The following is a description of a gene set: studied in species Homo sapiens The directed movement of chromosomes in the center of the spindle towards the spindle poles, mediated by the shortening of microtubules attached to the chromosomes. Human Gene Set: GOBP_CHROMOSOME_MOVEMENT_TOWARDS_SPINDLE_POLE, and this is the list of marker genes: KPNB1, CENPE, ACTR2, KATNB1, DLGAP5, ACTR3, FMN2